The following is a description of a gene set: Human Gene Set: GOBP_NEGATIVE_REGULATION_OF_NEURON_PROJECTION_DEVELOPMENT species: Homo sapiens Any process that decreases the rate, frequency or extent of neuron projection development. Neuron projection development is the process whose specific outcome is the progression of a neuron projection over time, from its formation to the mature structure. A neuron projection is any process extending from a neural cell, such as axons or dendrites (collectively called neurites)., and this is the list of marker genes: NEO1, WNT3, DAB1, CERS2, GFAP, MGARP, ULK1, FAT3, EPHA7, SPP1, SPOCK1, FIGNL2, DPYSL3, ARF6, DIP2B (NCBI Gene Id 57609), DTNBP1, TRPV4, LRIG2 (NCBI Gene Id 9860), STX1B (syntaxin 1B), RUFY3, CD38, LPAR1, CDK5, TNR, STMN3, NGEF, TSKU, KREMEN1, KIAA0319, INPP5F, DAB2, HDAC2, STMN2, ADCY6, TRIM46, AMIGO3, MIR210, MCF2, SLIT2 (NCBI Gene Id 9353), RTN4, RYK, CIB1, PTPRS, EFNB3, PTPN1, PAQR3, VIM, ARHGAP4, BAG5, MDM2, B2M, SEMA4F, GDI1, SLIT1, PLXNA3, EPHB2, CDH1, DCC, IL15RA, GAK, APOE, PTPN9, PAFAH1B1, ADAM17, FKBP4, EPHA4, DENND5A, SPART, RNF6, NR2F1, SEMA3F, PTPRG, RGMA, NEU4, MYLIP, TBX6, FGF13, NRP1, MINAR1, THOC2, MAP2, RAB29, PTPRO, TRAK2, ITM2C, RIT2, SEMA6C, PTEN, EFNB2, MAG, IFRD1, HES1, RTCA, PMP22 (peripheral myelin protein 22), RTN4RL2, SNAPIN, RTN4RL1, INPP5J, CRMP1, PRAG1, FSTL4, WNT3A, THY1, SEMA3G, ACP4, LRP4, SEMA5A, CBFA2T2, ULK2, LRRK2, ZNF365 (zinc finger protein 365), WNT5A, EFNA1, CDKL3, DGUOK, ZNF296, SYNGAP1, HDAC6, PSEN1, GFI1, BCL11A, SEMA3A, NTN1, DRAXIN, DKK1, NLGN1, KANK1, SEMA6D, MIR219A1, CARM1, MT3, RTN4R